Given this list of marker genes Chad, Ppargc1b, Cyp27b1, Fbn2, Col1a1, Thbs3, Msx2, Vegfa, Mmp2, Wnt10b, Vdr, Grem1, Enpp1, Sfrp1, here is a description of the gene set: Mouse Gene Set: GOBP_BONE_TRABECULA_FORMATION The process of creating a trabecula in the bone. A trabecula is a tissue element in the form of a small beam, strut or rod. studied in species Mus musculus